The following is a description of a gene set: Identification of the host genetic factors that contribute to variation in vaccine responsiveness may uncover important mechanisms affecting vaccine efficacy. We carried out an integrative, longitudinal study combining genetic, transcriptional, and immunologic data in humans given seasonal influenza vaccine. We identified genes exhibiting a transcriptional response to vaccination, significant genotype effects on gene expression, and correlation between the transcriptional and antibody responses. The results show that variation at the level of genes involved in membrane trafficking and antigen processing significantly influences the human response to influenza vaccination. More broadly, we demonstrate that an integrative study design is an efficient alternative to existing methods for the identification of genes involved in complex traits. DOI:http://dx.doi.org/10.7554/eLife.00299.001. Genes negatively correlated with antibody response in blood in adults (18-40) after exposure to Sanofi Pasteur, SA, Inactivated influenza vaccine, time point 0D Human Gene Set: FRANCO_BLOOD_SANOFI_PASTEUR_SA_INACTIVATED_INFLUENZA_VACCINE_CORRELATED_WITH_ANTIBODY_RESPONSE_AGE_18_40YO_0DY_NEGATIVE studied in species Homo sapiens from publication Franco LM, Bucasas KL, Wells JM, Niño D, Wang X, Zapata GE, Arden N, Renwick A, Yu P, Quarles JM, Bray MS, Couch RB, Belmont JW, Shaw CA (PMID 23878721), and this is the list of marker genes: NINJ2, MCRS1, AP3D1, GNA12, FSTL4, FBXO7, FBXO9, ACTG1, IL17REL, CAMK1G, ARPC2, ADIPOR1, CAMK2A, SPICE1